Given this list of marker genes KLHL8, BZW1, PDE3A, OR5V1, OBI1, TRPM2, SDC4, BMPER, SRRM4, LENG9, UBA1, HSPH1, FOXQ1, MEP1B, KCNQ4, LYZ, SGSM1, KCNK16, GNG5, FAM210B, GEM, RABGAP1L, MTOR, NAGA, MTCH2, BCL2L15, POLQ, TLNRD1, SLC22A3, ENTPD6, SOCS3 (NCBI Gene Id 9021), EMB, MECOM, LRRC3, EFS, ADGRV1 (adhesion G protein-coupled receptor V1), BMPR1B, FGF7, AGRN, PSD3, SHKBP1, KCNH2, SEC14L3, SMIM20, SLC16A13, SSBP2, ERG, PACSIN3, KLF10, HSD3B2, PDZK1, TMC5, ERI1, SNAI3 (NCBI Gene Id 333929), EIF3G, MALAT1, KRT78, ETF1, HMGN3, USP14, TAOK3, UVRAG, PRSS41, BVES, TEX35, HECTD3, DES, SNCB, GCH1, IL1RL1, SH3GL2, LCN10, DHX40, AXDND1, DHRS2, CDH8, CXCL6, PTGS1, P2RY14, HPCA, ATP6V0C, SIK3, C11orf52, TLR5, NMU, CCNK, EIF3D, IP6K2, COCH, DHX33, here is a description of the gene set: species: Mus musculus Phosphorylation is important in p53-mediated DNA damage responses. After UV irradiation, p53 is phosphorylated specifically at murine residue Ser389. Phosphorylation mutant p53.S389A cells and mice show reduced apoptosis and compromised tumor suppression after UV irradiation. We investigated the underlying cellular processes by time-series analysis of UV-induced gene expression responses in wild-type, p53.S389A, and p53(-/-) mouse embryonic fibroblasts. The absence of p53.S389 phosphorylation already causes small endogenous gene expression changes for 2,253, mostly p53-dependent, genes. These genes showed basal gene expression levels intermediate to the wild type and p53(-/-), possibly to readjust the p53 network. Overall, the p53.S389A mutation lifts p53-dependent gene repression to a level similar to that of p53(-/-) but has lesser effect on p53-dependently induced genes. In the wild type, the response of genes to UV irradiation was strictly biphasic. The early stress response, from 0 to 3 h, results in the activation of processes to prevent the accumulation of DNA damage in cells, whereas the late response, from 12 to 24 h, relates more to reentering the cell cycle. Although the p53.S389A UV gene response was only subtly changed, many cellular processes were significantly affected. The early response was affected the most, and many cellular processes were phase-specifically lost, gained, or altered, e.g., induction of apoptosis, cell division, and DNA repair, respectively. Altogether, p53.S389 phosphorylation seems essential for many p53 target genes and p53-dependent processes. Category C genes: p53-independent genes whose expression in the absence of S389 phosphorylation is dissimilar to loss of TP53 in MEF (embryonic fibroblast) cells in response to UV-C irradiation. from publication Bruins W, Bruning O, Jonker MJ, Zwart E, van der Hoeven TV, Pennings JL, Rauwerda H, de Vries A, Breit TM (PMID 18195040) Human Gene Set: BRUINS_UVC_RESPONSE_VIA_TP53_GROUP_C